Given this list of marker genes Tlr1, Cd1d1, Lbp, Tlr6, Tlr2, Cd1d2, here is a description of the gene set: Mouse Gene Set: GOMF_LIPOPEPTIDE_BINDING studied in species Mus musculus Binding to a lipopeptide, any of a group of organic compounds comprising two or more amino acids linked by peptide bonds and containing a nonprotein group consisting of a lipid or lipids.